The following is a description of a gene set: Genes down-regulated in plasmacytoid dendritic cell 7d vs 0d in young adults (18-50) after exposure to Fluarix/Fluvirin, time point 7D from publication Nakaya HI, Wrammert J, Lee EK, Racioppi L, Marie-Kunze S, Haining WN, Means AR, Kasturi SP, Khan N, Li GM, McCausland M, Kanchan V, Kokko KE, Li S, Elbein R, Mehta AK, Aderem A, Subbarao K, Ahmed R, Pulendran B (PMID 21743478) Human Gene Set: NAKAYA_PLASMACYTOID_DENDRITIC_CELL_FLUARIX_FLUVIRIN_AGE_18_50YO_7DY_DN species: Homo sapiens Here we have used a systems biology approach to study innate and adaptive responses to vaccination against influenza in humans during three consecutive influenza seasons. We studied healthy adults vaccinated with trivalent inactivated influenza vaccine (TIV) or live attenuated influenza vaccine (LAIV). TIV induced higher antibody titers and more plasmablasts than LAIV did. In subjects vaccinated with TIV, early molecular signatures correlated with and could be used to accurately predict later antibody titers in two independent trials. Notably, expression of the kinase CaMKIV at day 3 was inversely correlated with later antibody titers. Vaccination of CaMKIV-deficient mice with TIV induced enhanced antigen-specific antibody titers, which demonstrated an unappreciated role for CaMKIV in the regulation of antibody responses. Thus, systems approaches can be used to predict immunogenicity and provide new mechanistic insights about vaccines., and this is the list of marker genes: DNAJB6, YPEL1, BTBD3, RPA1, P4HB, TTC4, WDR43, ZBTB43, ARSB, RRP1B, OSBPL2, UBE2K, FAM131A, KMT2A, AMIGO2, UEVLD, CEP63, WWC3, CPSF4, HERC1, ANKFY1, SYS1-DBNDD2, UQCRFS1, HSPA13, NFATC2IP, API5, CIB2, TCTA, SYS1, MTMR6, SMG6, RFC4, CXCL2, RETREG2, SACS, ZNF3, RNF138, SEPTIN9, GPX3, METTL22, DPP4, ZNF212, FDX1, ARMCX5, BTN2A2, FBXL5, ICAM2, SAT1, GMPR2, TPM2, COPS6, SPRED2, ENTPD7, CPT1A, USP3, GNA11, GSTZ1, USP46, TLR6, MID2, PRDX6, ZKSCAN5, FBXO38, MAPRE2, CREBZF, RAE1, N4BP1, CDC23, CENPS, SEC23B, EWSR1, DCTN4, SLC12A7, RASA4, MORC4, NDST2, NCOR2, LONP2, TPRKB (NCBI Gene Id 51002), DUS4L (NCBI Gene Id 11062), SDAD1, B3GALT2, NANOG, TLK1, FASTKD3 (NCBI Gene Id 79072), BRCC3, LRFN4 (NCBI Gene Id 78999), EGR2, COQ10B, MORC2, ELMO2, SLC9A6, WDR13, ZNF589, BCS1L, DDX49, SLC8A2, MTF2, SPIN2A, CD84, DSE, YOD1, PIK3R1, GIPC1, MADD (MAP kinase activating death domain), GRK3, KLC2, ZFP64, GNL3L, NDUFA5 (NADH:ubiquinone oxidoreductase subunit A5), CSTF1, BDH1, RAB11A, PPP2R2A, H1-0, CFP, CES2, RBM12B-AS1, ALG13, SOCS5, CUL5, JAG1, SLC38A4, EIF4ENIF1, RXRB, ATP5MG, TRIM36, ZKSCAN7, GNMT, MAP4K5 (NCBI Gene Id 11183), NUP98, PRC1, STXBP6, YBX2, GNG10, MTERF3 (mitochondrial transcription termination factor 3), KNOP1, SCN3B, PDE4B, GLMN, HSPA1L, ESR2, MRPL9, PNPLA2, GAS1, PTEN, MEF2D, FRAS1, RASA4B, GK, MPIG6B, NOP14, PRPF4, CACFD1, IL13RA1, NABP1, IFI44, MAPK14, EPHA2, LILRB4, SPATA20, RPL37A, PHLPP1, TAF6L, PAXBP1, POMZP3, SGCB, IL11RA (NCBI Gene Id 3590), NUP133, LUC7L2 (LUC7 like 2, pre-mRNA splicing factor), AKAP11, DNAJC24, RGS14, EML2, FH, ASNS, LRP10, CSAD, PTPN11, DBNDD2, SH3BGRL, RHEB, PRKCI, MYCL (MYCL proto-oncogene, bHLH transcription factor), CDK17, P2RY1, CCNL2, NR3C1, BCAT1, PIP5K1B, KLF11, USP9X, ERGIC2, NAIP, THBD, CKAP5